Given this list of marker genes NF2, PAK2, MYH11, PPP1R12A, MYH14, PPP1R12B, CALM1, MYH9, PAK1, CTTN, FLNA, MYH10, LIMK1, PAK3, MYL12B, MYLK, CDC42, MYL6, RAC1, MYL9, PPP1CB, here is a description of the gene set: species: Homo sapiens Human Gene Set: REACTOME_RHO_GTPASES_ACTIVATE_PAKS RHO GTPases activate PAKs